Given this list of marker genes RPL4, RPL13A, RPL36A, UBA52, RPL30 (ribosomal protein L30), UBB, FAU, RPL18, RPL3, UBC, ZNF598, RPL12, RPL15, TRIP4, RPL17, RPS5, UBE2D2, RPL10, RPL7A, RPLP1, RPL36, RPL34, RPL14 (ribosomal protein L14), RPS25, RPL21, ASCC3, RPS8, RPLP0, RPS4Y1, RPS27, RPS29, RPS24, RPS21, RPS4X, RPS27A (NCBI Gene Id 6233), RPL8, RPL26L1, RPL22, UBE2D3, RPL38, RPL7, RPL27A, RPS15A, RPL35A, RPL9, RPL23A, RPS20, RPS23 (NCBI Gene Id 6228), RPL32, RPL6, UBE2D1, RPL37, RPS15, RPL18A, RPL39, RPS26, RPL31, RPL13 (NCBI Gene Id 6137), RPL10A, RPL24, RPL37A, RPS9, RPL11, RPL41, RPS16, RPS14, RPS28, RPL5, RPS17, RPL26, RPL28, RPS6, 5S rRNA, RPS18 (ribosomal protein S18), RPL3L, RPS3, RPL39L, RPL10L, RPS2, RPS13, RPL35, RPL19, RPS12, RPL29 (ribosomal protein L29), 18S rRNA, RPS7, RPLP2, RPL23, RPL36AL, RPS19, RPL22L1, RPSA, RPL27 (NCBI Gene Id 6155), RPS10, RPS27L, RPS3A (NCBI Gene Id 6189), ASCC2 (NCBI Gene Id 84164), 28S rRNA, 5.8S rRNA, RPS11, RPS4Y2, here is a description of the gene set: studied in species Homo sapiens Due to features such as damaged nucleotides, strong secondary structure, presence of stretches of more than four uninterrupted AAA codons in a mRNA coding region (designated no-go mRNAs) a ribosome translating an mRNA can stall and cause collisions with the ribosomes trailing it on the mRNA. In cases in which the ribosome stalls internally on the mRNA and a 3' region of the mRNA protrudes from the ribosome, ZNF598, a ubiquitin E3 ligase that is the homolog of yeast HEL2, binds the ribosome and ubiquitinates the 40S subunit ribosomal proteins eS10 (RPS10) at residues K138 and K139 and uS10 (RPS20) at residues K4 and K8 to initiate splitting of the 40S and 60S ribosomal subunits. ZAKα also interacts with the collided ribosome at the 18S helix through its c-terminal domain, which triggers ZAKα autophosphorylation and phosphorylation of p38/JNK in a MAPK cascade known as the ribotoxic stress response.<br>The ASCC2 subunit of the ribosome quality control trigger complex (RQT complex, ASCC2:ASCC3:TRIP4) binds K63-linked polyubiquitin conjugated to the 40S protein uS10. The ASCC3 subunit of the RQT complex splits stalled 80S ribosomes with K63-polyubiquitinated uS10 into 60S and 40S subunits apparently by exerting a pulling force on the mRNA (inferred from the yeast homolog Slh1 in Best et al. 2023). The peptidyl-tRNA remains bound in the 60S subunit, with the tRNA positioned in the P site. The problematic mRNA dissociates after splitting and is thought to be degraded at this time. In the case of collided yeast ribosomes, the mRNA is first endonucleolytically cleaved and the cleavage products are exonucleolytically degraded by XRN1 and the exosome. Reactome Pathway: ZNF598 and the Ribosome-associated Quality Trigger (RQT) complex dissociate a ribosome stalled on a no-go mRNA part of: Ribosome-associated quality control